The following is a description of a gene set: Genes predicted to be targets of miRBase v22 microRNA hsa-miR-636 in miRDB v6.0 with MirTarget v4 prediction scores > 80 (high confidence targets). from publication Chen Y, Wang X (PMID 31504780) studied in species Homo sapiens Human Gene Set: MIR636, and this is the list of marker genes: NPY1R, AMER2, CROT, JADE3, COLGALT1, SOCS3, TOB1, CNOT6, PHC3, ANKRD44, ZFYVE26, NR2C1, NUMB, TPD52, TMEM150C, ZDHHC8, HCFC1, NR1D2, YWHAZ, INTS6, CCDC89, SLK, SERTAD2, NDRG4, PCDHA12, SAXO2, CNOT7, RIMKLB, ITM2C, HECTD2, STAM2, PCDHA13, RTN3, TMEM25, DCLK1, IL20RA, DOCK9, MED17, PCDHA10, GNB1, ARID4B, ADRB1, LRRC75B, SLC6A17, CBLN3 (NCBI Gene Id 651052), STATH, RCBTB1 (RCC1 and BTB domain containing protein 1), CISD1, SLC6A1, SCAF11, TCF20, RET, MDGA2, RNF139, ITGA9, B3GAT1, ZFX, CDC42SE2, MIER3, NEURL4, MARCHF4, FIGN, GFRA1, ZNF831, ARB2A, PCDHAC2, JADE2, TMEM178A, RAP1A, UBE2E2, UBR3, CETN2, C3orf70, PSEN1, SPSB1, LINC03034, UQCR10, PNPLA8 (NCBI Gene Id 50640), DCAF5, PFKM (phosphofructokinase, muscle), MDGA1, RELN, LDOC1, MKNK2 (NCBI Gene Id 2872), P2RX4 (NCBI Gene Id 5025), MAST4, SGCZ, PIEZO2, VOPP1, CILK1, SOX5, YTHDF3, ABCG4, TMEM132E-DT, TBX15, EMX2, RUNX2, GLCE, HOXD10, CHST8, TNRC6C, MKX, MINDY2, DLG2, KCNE1, VAMP7, RIMS3, COMMD3-BMI1, TCF4, EPB41L1, TMEM182, INSYN2B, ERC2, ADAM22, VSIG10, SCN9A, FREM2, SETBP1, ABRA, GASK1B, PCGF2, KDELR3, MYORG, ARF6, INHBB, RIMBP2 (NCBI Gene Id 23504), NRXN1, VAT1, FAM78A, RIMS1, BRINP3, RECQL5, KLHL5, L3MBTL3, GNG3, SENP1, KLHL29, DCAF6, MBNL2, ONECUT2, RPS6KA2, PLXNA4, YWHAB, FCHO2, JMY, RBPJ, FGF12 (fibroblast growth factor 12), KLHL18 (kelch like family member 18), RABGAP1L, PTPRA, ADCY9, TRIM71, NCAN, SHTN1, ACSL1, KLF9, HOXA10, SAMD8, MAFG, SAMD12, HIVEP1, EBF3, PCDHA11, AP3M1, CSMD3, SFRP2, PRLR, KRTAP1-3, EPHA7, LASP1, VPS53, KIRREL3, DCBLD2, RPA3, PPME1, IPO8, PCDHA3, ROBO2, SNX4 (sorting nexin 4, NCBI Gene Id 8723), LRIG1, GRIP1, FBRSL1, HIPK1, MYSM1, ARK2C, SFMBT1, KCNIP3, SPECC1L, YEATS4, NUP50, SHISA6, GRIK2, HAPLN1, NUFIP2, ITGB6, TMEM129, TMEM132B, PCDHA4, TUB, PCDHA1, MOSPD1, KCNH1, DCDC2, ZNF468, EIF5A2, FRMD4B, HP1BP3, PCDHA2, PCDHA7, RICTOR (RPTOR independent companion of MTOR complex 2), HTN3, RPS6KA3, SEMA4A, TRIM9, NMT2, PCDHAC1, RCOR1, CHM (NCBI Gene Id 158677), RAB6A, LPCAT1, DCUN1D4, PCDHA6 (protocadherin alpha 6), LYSMD3, TMEM163, PCDHA5, KLF8